The following is a description of a gene set: Chaperonin-mediated protein folding Mouse Gene Set: REACTOME_CHAPERONIN_MEDIATED_PROTEIN_FOLDING studied in species Mus musculus, and this is the list of marker genes: Pdcl, Gnb2 (guanine nucleotide binding protein (G protein), beta 2), Gnb4, Rgs7, Gng7, Gnb3, Sphk1, Gng4, Gngt2, Gngt1, Rgs9, Cct6a, Gnb5, Tcp1, Gng8, Gnb1, Gng2, Gna14, Cct3, Gnaq, Cct8, Rgs11, Cct5, Cct7, Csnk2a1, Gng11, Gna11, Gng13, Cct2, Gng12, Rgs6, Gng5, Cct4, Csnk2b, Gng3, Csnk2a2, Gna15, Cct6b, Gng10